Given this list of marker genes FOLH1B, NAALADL1, CPM, CPXM1, CPQ, CPXM2, CNDP1, PEPD, CPZ, CPB2, CPB1, ACE, MINDY1, CPN1, LAP3 (leucine aminopeptidase 3), CPE, CPA6, CPA4, PM20D2 (NCBI Gene Id 135293), CPA2, CPO (carboxypeptidase O), MINDY2, NAALAD2, AGBL1, CPA3, PREP, AGBL4, PRCP, CTSA, CPD, MATCAP1, VASH2, CNDP2, CPVL, CPA1, AGBL3, AGTPBP1, BLMH, CTSZ, SCPEP1, MATCAP2, AGBL2, AGBL5, AEBP1, ACE2, CPA5, MME, FOLH1, VASH1, here is a description of the gene set: Catalysis of the hydrolysis of a single C-terminal amino acid residue from a polypeptide chain. studied in species Homo sapiens Human Gene Set: GOMF_CARBOXYPEPTIDASE_ACTIVITY